Given this list of marker genes Ripk1 (NCBI Gene Id 328217), Bex3, Ngf, Tmbim1, Prdm4, Tnfsf15, Dab2ip, Nol3, Bdnf, Fasl, Ntf5, Edaradd, Ntf3, Nsmaf, Cflar, Casp8, Eda, Fadd (Fas associated via death domain), Fem1b, Casp3, here is a description of the gene set: studied in species Mus musculus Binding to a member of the death receptor (DR) family. The DR family falls within the tumor necrosis factor receptor superfamily and is characterized by a cytoplasmic region of ~80 residues termed the death domain (DD). Mouse Gene Set: GOMF_DEATH_RECEPTOR_BINDING